The following is a description of a gene set: Any process that stops, prevents or reduces the frequency, rate or extent of dendritic cell differentiation. species: Homo sapiens Human Gene Set: GOBP_NEGATIVE_REGULATION_OF_DENDRITIC_CELL_DIFFERENTIATION, and this is the list of marker genes: LILRB1, CLEC12A, TMEM176B, HLA-G, FCGR2B, ZBTB46, TMEM176A